The following is a description of a gene set: species: Homo sapiens Human Gene Set: REACTOME_SARS_COV_1_ACTIVATES_MODULATES_INNATE_IMMUNE_RESPONSES SARS-CoV-1 activates/modulates innate immune responses, and this is the list of marker genes: FKBP1A, MAVS, UBB, TRAF6, STING1, PYCARD, ITCH, NMI, CASP1, SFTPD, RUNX1, PPIG, PPIA, RELA, NPIPB3, RIGI, UBC, PPIB, KPNB1, IRAK2, NFKBIA, PCBP2, RIPK3, TKFC, TRIM25, TOMM70, NLRP3, TRAF3, BST2, PPIH, KPNA2, RCAN3, TBK1, TLR7, RPS27A, IFIH1, UBA52, SIKE1, IKBKE, NFKB1, IRF3